Given this list of marker genes CHRM3, PRKCB, GNA11, CHRM1, GNA15, CHRM2, ITPR1, PLCB1, here is a description of the gene set: Human Gene Set: GOBP_PHOSPHOLIPASE_C_ACTIVATING_G_PROTEIN_COUPLED_ACETYLCHOLINE_RECEPTOR_SIGNALING_PATHWAY studied in species Homo sapiens A phospholipase C-activating G protein-coupled receptor signaling pathway initiated by acetylcholine binding to its receptor on the surface of a target cell, and ending with the regulation of a downstream cellular process, e.g. transcription.